Given this list of marker genes MIR2114, MTM1, PHF10P1, ATP6AP1, EMD, MIR718, GABRA3, BRCC3, NAB1P1, MAGEA8-AS1, SLC6A8, HSFX3, F8, CNGA2, G6PD, GABRQ, CETN2, AVPR2, IKBKG, FATE1, UBL4A, OPN1LW, ABCD1, IDS, H2AB3 (NCBI Gene Id 83740), MAGEA9B, MAGEA5P (MAGE family member A5, pseudogene), L1CAM-AS1, TRPC6P1, FTH1P8, VBP1, RPL12P50, ENSG00000266560, SRD5A2P1, PWWP4, CLIC2, AMD1P2, RPL18AP16, FAM3A (FAM3 metabolism regulating signaling molecule A), MIR664B, OPN1MW, ZNF185, TMLHE, PNMA6E, XRCC6P2, HMGN2P48, MRFAP1P1, RPL10, PLXNB3 (NCBI Gene Id 5365), HAX1P1, KRT18P48, RPL19P21, ENSG00000273877, MIR224, MAGEA6, VMA21, MAGEA10, HMGN1P37, ECMXP, OPN1MW3, MAGEA2, MTCP1, MECP2, CTAG2, LAGE3, EOLA1-DT, F8A2, MAGEA12, MAGEA3-DT, ATF4P1, LINC02927, EOLA1, ENSG00000305574, RN7SL667P, DDX11L16, HCFC1-AS1, IKBKGP1, RPL7L1P11, WASIR1, ATP6AP1-DT, TMEM187, SNORA70, EOLA2-DT, GDI1, ZNF622P1, ATP2B3, PNMA5, RNA5SP524, MPP1, TMLHEP1, MIR3202-1, ELOCP24, MAMLD1, WASH6P, MAGEA6-DT, IRAK1, GPR50-AS1 (GPR50 antisense RNA 1), IDH3G (NCBI Gene Id 3421), ATF4P2, OR3B1P, NAA10, CSAG3, PNMA6B, ZFP92, BCAP31, CCNQ, CMC4, HSFX4, TAFAZZIN, MIR105-2, TREX2, MAGEA2B, SPRY3, PASD1, SNORA56, TWF1P2, F8A1, ENSG00000293160, PNMA6A, HSFX1, PLXNB3-AS1, MAGEA9, SRPK3, MAGEA3, MAGEA4-AS1, BGN, SMIM9, TMEM185A, NSDHL, FAM223A, HMGB3, RN7SL687P, MAGEA1 (MAGE family member A1), RPSAP60, HAUS7, ZNF275, VAMP7, EOLA2, MAGEA7P, RN7SL697P, FAM50A, PDZD4, GABRE, DPH3P2, PPIAP91, MIR4330, RNU6-383P, HCFC1, FAM223B, PLXNA3, ENSG00000286939, ARHGAP4 (Rho GTPase activating protein 4), IDSP1, MIR105-1, CD99L2, TKTL1, GAB3, CTAG1B, SSR4 (signal sequence receptor subunit 4), PRRG3, TMLHE-AS1, DKC1, DUSP9, L1CAM, EEF1A1P31, MAGEA4, CSAG1, MIR452, HSFX2, RNU6-764P, TEX28P2, ENSG00000287585, MIR767, F8A3, MIR1184-3, MIR3202-2, KRT8P8, CTAG1A, TEX28, SLC10A3, MAGEA8, SNORA36A, MIR6858, MIR1184-1, PNMA6F, DUTP4, H2AB1, LINC00850, TEX28P3, FUNDC2, AFF2, MTMR1, TMEM185AP1, PNMA3, CSAG4, CSAG2, PNCK, AFF2-IT1, IL9R, MAGEA11, DNASE1L1, TEX28P1 (TEX28 pseudogene 1), GPR50, RENBP, RAB39B, H2AB2, RNA5SP525, FLNA, MIR1184-2 (microRNA 1184-2), CD84P1 (NCBI Gene Id 118568807), OPN1MW2, RN7SKP267, CYCSP45 (NCBI Gene Id 352852), here is a description of the gene set: studied in species Homo sapiens Human Gene Set: chrXq28